Given this list of marker genes ALOX5, IL18BP (NCBI Gene Id 10068), IL4, IL13 (NCBI Gene Id 96500), IL18, IL37, IL18RAP, IL18R1, here is a description of the gene set: part of: Interleukin-1 family signaling Interleukin-18 (IL18, pro-IL18) is a pleiotropic and pro inflammatory cytokine. It belongs to the Interleukin-1 (IL1 superfamily. IL18 is synthesized as an inactive 24-kDa precursor protein that is cleaved by extracellular proteases such as caspase-1, protease 3, serine protease, elastase or cathepsin G (Fantuzzi & Dinarello 1999, Gracie et al. 2004, Sugawara et al. 2001), forming an 18-kDa mature protein. <br>IL18 also occurs as a short isoform, the result of an alternative splicing event that removes 57 bp/19 aa (IL18alpha). This short isoform has a modest synergistic action with the IL18 canonical active form. The IL18 receptor (IL18R) belongs to the Interleukin-1 receptor/Toll like receptor superfamily. It consists of two subunits, Interleukin-18 receptor 1 (IL18R1, IL-18Rα, IL1Rrp1, IL18R1, IL-1R5) and Interleukin-18 receptor accessory protein (IL18RAP, IL18RB, IL-18Rβ,IL-18RacP, IL-18RII or IL-1R7). Both subunits have three extracellular immunoglobulin-like domains and one intracellular Toll/IL-1 receptor (TIR) domain (O'Neill & Dinarello 2000, Sims 2002). It is believed that IL18 binds first to IL18R1 and later recruits IL18RAP to form a high-affinity heterotrimeric complex. A short isoform of IL18R1 lacks the TIR domain (IL18R1 type II), which is required for signaling, leading to the suggestion that IL18R1 type II is a decoy receptor. A truncated form of IL18RAP containing only one of the three immunoglobulin domains stabilizes IL18 binding to IL18R1 but prevents signaling.<br>IL-18 binding protein (IL18BP), a 38-kDa soluble protein, is another negative regulator of IL18 signaling. It has some sequence homology with IL18R1. IL18BP binds with high affinity to mature IL18, preventing its interaction with IL18R1. Several isoforms IL18BP have been described. Interleukin-37 (IL37, IL-1F7), another negative regulator of IL18 signaling, is able to bind IL18BP and IL18RAP preventing signaling (Bufler et al.2002, Pan et al. 2001, Kumar et al. 2002).<br>IL18 stimulates Interferon gamma (IFNG, IFN-γ) production from T-helper lymphocytes cells (Th1) and macrophages and enhances the cytotoxicity of natural killer (NK) cells. IL18 stimulated IFNG production is synergistically amplified by other Th1-related cytokines such as IL2, IL15, IL12 and IL23 (Boraschi & Dinarello 2006, Park et al. 2007, Dinarello 2007, Dinarello & Fantuzzi 2003). Reactome Pathway: Interleukin-18 signaling species: Homo sapiens